Given this list of marker genes CTSC, RNASEH2B, MT-TQ, GJA1, MT-TH, ACP5, AMER1, HLA-DQB1, LSM11, TNFRSF11A, ACD, CSF1R, SC5D, SLC19A1, TCIRG1, EXOSC2, PSMB8, SMARCB1, IRF8, DDR2, PSMG2, HLA-DQA1, USP18, CYP2U1, OCLN, STAT2, CLCNKB, SLC20A2, SLC46A1, NOP10, SLC26A2, NRAS (NCBI Gene Id 4893), GNA11, SUCLA2, ISG15, RNASEH2A, MT-CO3, MT-TF, CMPK2 (NCBI Gene Id 129607), KRAS, JAM2 (junctional adhesion molecule 2), PARN, FAM111A, WRAP53, KRIT1, NHP2, ODC1, ZNFX1, PTCH1, TINF2, KL, ERCC6, TERC, POT1, PTCH2, ERCC5, MT-ND5, RTEL1, SLC2A1, MT-ND6, WWOX, MYMX, COLGALT1, COL11A1, PSMB9, DENND5A, OPA1, PAH, MGP, MYO5A (myosin VA), XPR1, RNASEH2C, PEX1, MYORG, NPM1, MT-TL1, TYMS, PDGFB, ZBTB20, PTH, SNRPB, VPS33A, DAG1, TREX1, TSC1, PPFIBP1, TYROBP, ERCC3, MT-TS2, CPT2, MT-CO2, SLC29A3, NSMCE3, IFNG, SLC12A3, GNAS, SLC4A4, CA2, ERCC4, ABCC6, CASR, FGFR1, PDGFRB, NDE1, SUFU, DNM1L, CTC1, ESAM, MYMK, KARS1, TSC2, APP, PEX6, BRAF, SLC25A46, AIRE, ERCC2, CTNNB1, DKC1, ADAR, MT-ND1 (mitochondrially encoded NADH:ubiquinone oxidoreductase core subunit 1), FAM20C, SAMHD1, IFIH1, SNORD118, NAA60, KATNB1 (NCBI Gene Id 10300), ACVR1, FARSB, AP1S2, MT-ND4, ZSWIM6, TERT, MT-CO1, RNU7-1, QDPR, TREM2, RNASET2 (NCBI Gene Id 8635), GATA3, GNAQ, ECM1, RELN, ENPP1, USB1, ERCC8, COL2A1, CTNS, RBBP8, MT-TW, ERCC1, ATP7A, HRAS, here is a description of the gene set: The presence of calcium deposition within the cerebrum. Cerebral calcification species: Homo sapiens Human Gene Set: HP_CEREBRAL_CALCIFICATION